Given this list of marker genes ARX, FEZF1, RAC1, NR2F2, PAFAH1B1, CNTN2, LHX6, CCR4, EVX1, DRD1, RELN, DRD2, FAT3, NKX2-1, SOX1 (SRY-box transcription factor 1), FEZF2, here is a description of the gene set: The orderly movement of an interneuron from one site to another. Human Gene Set: GOBP_INTERNEURON_MIGRATION studied in species Homo sapiens